Given this list of marker genes DEPP1, AMN, LINC00472, BMP3, ACSM3, CEBPD, here is a description of the gene set: Human Gene Set: HE_LIM_SUN_FETAL_LUNG_C5_DELTA_SMALL_PRE_B_CELL species: Homo sapiens from publication He P, Lim K, Sun D, Pett JP, Jeng Q, Polanski K, Dong Z, Bolt L, Richardson L, Mamanova L, Dabrowska M, Wilbrey-Clark A, Madissoon E, Tuong ZK, Dann E, Suo C, Goh I, Yoshida M, Nikolić MZ, Janes SM, He X, Barker RA, Teichmann SA, Marioni JC, Meyer KB, Rawlins EL (PMID 36493756) λ small pre-B